The following is a description of a gene set: species: Homo sapiens Cell differentiation - expanded index Human Gene Set: WP_CELL_DIFFERENTIATION_EXPANDED_INDEX, and this is the list of marker genes: KLF4, MIR199A2, MIR302C, MIR143, MIR302D, MIR486-1 (NCBI Gene Id 619554), MIR222, MIR133A1, MIR221, LEFTY2, MIR106A, STAT3, MIR17, MIR146B, MIR20A (microRNA 20a), MEF2C, MYOD1, MIR26A2, MEF2B, TLX2, ID2, MIR16-2, MIR133A2, MIR9-1, LEFTY1, MIR181B1, MIR3074, HDAC5, MIR486-2, MIR145, TLX1, MIR133B, MIR181A2, MIR128-1, MIR3591, MEF2A, MIR26A1, PAX7, MIR302E, SRF (serum response factor), MIR206, MIR214, MIR181B2, MIR181D, MIR181C, MEF2D, BORCS8-MEF2B, MIR150, TLX3, MIR1-1, MIR302A, EZH2, MIR16-1, MIR223, MIR181A1, MIR203A, RUNX2, SOX2, MIR199A1